Given this list of marker genes Ffar3, Nlgn2, Tac1, Nmu (neuromedin U), Rims1, S100b, Fgfbp3, Mag, Mir23a, Rapgef4, Nlgn3, Qki (quaking, KH domain containing RNA binding), Tnr, Trf, Pawr, Itga2, Gba1, Srebf2, Ngfr, Cst7, Cartpt, Dicer1, Igsf9b, Sox10, Nrdc, Cntnap2, Rnf10, Il6 (NCBI Gene Id 16193), Ncmap, Tppp, Pard3, Grin2a, Tac4, Hgf, Hcrt, Abat, Cdk18 (cyclin dependent kinase 18), Rims2 (regulating synaptic membrane exocytosis 2), Myrf, Dag1, Zfp488, Egr2, Sgms1os1, Ntsr1, Slc25a12, Itgax, Mtnr1b, Igf1, Chrnb4, Tenm4, Unc13b, Hnrnpk, Atpsckmt, Tnfrsf1b, Wasf3, Grin2b, here is a description of the gene set: Any process that activates or increases the frequency, rate or extent of a neurophysiological process. species: Mus musculus Mouse Gene Set: GOBP_POSITIVE_REGULATION_OF_NERVOUS_SYSTEM_PROCESS